Given this list of marker genes GATA3, OLIG3, HDAC1, ATOH7, HIF1A, CRY1, ATOH8, BHLHE40, HAND2, NEUROD1, TCF3, SCX, TCF15, TCF12, NEUROG3, PTF1A, NR1D1, MYOG, ASCL1, TCF21, MAX (NCBI Gene Id 4149), TAL1, SNAI1, MYF6, BHLHA15, BHLHE41, TCF4, MITF, MYF5, OLIG1, NEUROD2, NEUROG1 (NCBI Gene Id 4762), BMAL2, SNAI2 (NCBI Gene Id 6591), BHLHE23, MYBBP1A, NEUROG2, ATOH1, AHR, PRMT5 (NCBI Gene Id 415048), PPARG, SREBF2, CIART, BMAL1, TFAP4, FIGLA, HES1, PER1, MYOD1, OLIG2, NEUROD4, SCRT2, TWIST1, ASCL2, CLOCK (clock circadian regulator), MYC, NEUROD6, BHLHE22, ZEB1, here is a description of the gene set: Human Gene Set: GOMF_E_BOX_BINDING studied in species Homo sapiens Binding to an E-box, a DNA motif with the consensus sequence CANNTG that is found in the promoters of a wide array of genes expressed in neurons, muscle and other tissues.